Given this list of marker genes Opn4 (NCBI Gene Id 30044), Slc17a6 (solute carrier family 17 (sodium-dependent inorganic phosphate cotransporter), member 6), Opn5, Th, Flt1, Slc6a3, Ninj1, Drd2, here is a description of the gene set: The developmental process in which the hyaloid vascular plexus is destroyed as a part of its normal progression. studied in species Mus musculus Mouse Gene Set: GOBP_HYALOID_VASCULAR_PLEXUS_REGRESSION